The following is a description of a gene set: part of: Signaling by Receptor Tyrosine Kinases Inflammatory mediators such as growth factors produced by macrophages play an important role in the inflammatory response occurring during bacterial infection, tissue injury and immune responses. Many growth factors and their receptor-type protein tyrosine kinases (RTKs) play a critical role in inflammation, wound healing and tissue remodelling. The growth factor hepatocyte growth factor-like protein (MST1, also known as macrophage-stimulating protein, MSP) binds to a specific receptor, macrophage-stimulating protein receptor (MST1R, also known as RON, recepteur d'origine nantais). MST1 belongs to the kringle protein family, which includes HGF and plasminogen. It is produced by the liver and circulates in the blood as a biologically-inactive single chain precursor (pro-MST1). Proteolytic cleavage of pro-MST1 into the biologically-active MST1 dimer is necessary for receptor binding. Cleavage occurs during blood coagulation and at inflammatory sites, the resultant MST1 dimer then binds MST1R receptors on local macrophages. MST1R is ubiquitously expressed but mainly in epithelial cells.<br><br>MST1 binding to MST1R promotes receptor homodimerisation which in turn allows autophosphorylation of two tyrosine residues within the catalytic site which regulates kinase activity and allows phosphorylation of the carboxy-terminal binding site of the receptor. The docking site is essential for downstream signaling through direct and indirect binding of SH2 domain-containing adaptor proteins such as GRB2, PI3K, and SRC. MST1/MST1R signaling plays a dual role in regulating inflammation; initially stimulating chemotaxis and phagocytosis (macrophage activation) and then exerts broad inhibitory effects on macrophages, limiting the extent of inflammtory responses. MST1R is upregulated in many epithelial cancers where it is thought to play a role in the progression of these types of cancer. Reactome Pathway: Signaling by MST1 studied in species Homo sapiens, and this is the list of marker genes: SPINT1, MST1R, MST1, SPINT2, HPN